Given this list of marker genes Sox9, Sox18, Sfrp1, Gsc, Sox17, Sfrp2, Dmrta2, Bmpr1a, Ednra, Edn1, here is a description of the gene set: The process in which the developmental fate of a cell becomes restricted such that it will develop into a stem cell. studied in species Mus musculus Mouse Gene Set: GOBP_STEM_CELL_FATE_COMMITMENT